Given this list of marker genes HSD17B11, FGF23, CYP24A1, CYP46A1, SRD5A1, SPP1, SULT1E1 (NCBI Gene Id 6783), SCARF1, CYP19A1, SRD5A2, HSD17B6, CYP27B1, CYP3A4 (cytochrome P450 family 3 subfamily A member 4), SCARB1, CYP7A1, SNX17, HSD17B14, CYP1A2, CYP39A1, HSD11B1, YWHAH, STS, AKR1D1, APOE, CYP27A1, here is a description of the gene set: species: Homo sapiens Human Gene Set: GOBP_STEROID_CATABOLIC_PROCESS The chemical reactions and pathways resulting in the breakdown of steroids, compounds with a 1,2,cyclopentanoperhydrophenanthrene nucleus.